Given this list of marker genes Dlst, Dld, Mrps36, Amt, here is a description of the gene set: electronically inferred by orthology from the curated human pathway part of: Glyoxylate metabolism and glycine degradation species: Mus musculus This event has been computationally inferred from an event that has been demonstrated in another species.<p>The inference is based on the homology mapping from PANTHER. Briefly, reactions for which all involved PhysicalEntities (in input, output and catalyst) have a mapped orthologue/paralogue (for complexes at least 75% of components must have a mapping) are inferred to the other species. Reactome Pathway: Glycine degradation